The following is a description of a gene set: species: Mus musculus Mouse Gene Set: GOBP_PROTEIN_LOCALIZATION_TO_CELL_SURFACE A process in which a protein is transported to, or maintained in, a location within the external part of the cell wall and/or plasma membrane., and this is the list of marker genes: Astn2, Slc28a2, Fgf7, Cd247, Agap2, Leprot, Tax1bp3, Ctnnb1, Map1a, Hsp90ab1, Abca2, Cdh1, Vps54, Ric3, Ank2, Tsc2, Tnf, Picalm, Kcnab2, Plk2, Gbf1, Stx4a, Gpm6b, Mesd, Gopc, Snx33, Tyrobp, Rab11a, Abca7, Arf6, Rab11b, Unc50, Tor1a, Gga1, Hfe, Stx3, Abcc1, Rangrf, Angpt1, Jam3, Tm9sf4, Cd177, Ephb2 (NCBI Gene Id 13844), Egf, Gpd1l, Nlgn2, Rab11fip5, Abca12, Commd1, Erbb4, Vcl, Gpihbp1, Wnt11, Usp4, Flna, Fbln5, Gga3, Actn2, Lrig2, Ap3b1, Akt1, Emp2, Fgf10 (fibroblast growth factor 10), Ptpru, Tmem35a, Ptprk, Washc1, Fcnb, Prrt1, Slc28a2b, Hnrnpk, Synj2bp, Nedd4l, Fcer1g, Gga2 (NCBI Gene Id 74105)